The following is a description of a gene set: Cervical cancer is associated with human papilloma virus infection. However, this infection is insufficient to induce transformation and progression. Loss of heterozygosity analyses suggest the presence of a tumor suppressor gene (TSG) on chromosome 6p21.3-p25. Here we report the cloning NOL7, its mapping to chromosome band 6p23, and localization of the protein to the nucleolus. Fluorescence in situ hybridization analysis demonstrated an allelic loss of an NOL7 in cultured tumor cells and human tumor samples. Transfection of NOL7 into cervical carcinoma cells inhibited their growth in mouse xenografts, confirming its in vivo tumor suppressor activity. The induction of tumor dormancy correlated with an angiogenic switch caused by a decreased production of vascular endothelial growth factor and an increase in the production of the angiogenesis inhibitor thrombospondin-1. These data suggest that NOL7 may function as a TSG in part by modulating the expression of the angiogenic phenotype. species: Homo sapiens Genes up-regulated in SiHa cells (cervical carcinoma) by stable expression of NOL7 off a plasmid vector. from publication Hasina R, Pontier AL, Fekete MJ, Martin LE, Qi XM, Brigaudeau C, Pramanik R, Cline EI, Coignet LJ, Lingen MW (PMID 16205646) Human Gene Set: HASINA_NOL7_TARGETS_UP, and this is the list of marker genes: RTN1, PLAUR, ADM, CD70, F3, CD59, TIMP2, TFPI, NEO1, TIMP1, SOS2, HIF1A, CD99